Given this list of marker genes CBLC, SMAP2, ITPK1, GLO1, SLC44A1, IBTK, SLC35G1, IVD (NCBI Gene Id 3712, isovaleryl-CoA dehydrogenase), TMEM176A, GRPEL2, CCT8, SCD, RICTOR, ILVBL, ENPP3, SLC6A8, SPSB4, TMCC3, FNIP1, MAPK1IP1L, AVL9, GNAQ, KRT23, ABHD1, CA1, APH1A, RORA, CCM2L, GRAMD2B, TMEM70, WDR11, MCL1, RHOU, CMTM4, MYSM1, SERPINA7, ZC3H12C, LPL, ATP11A, TRAF4, PTGFRN, NIBAN2, TBC1D7, SLC25A39, SDR39U1, TENT2, SMURF2 (SMAD specific E3 ubiquitin protein ligase 2), HYCC1, SERPINA6 (serpin family A member 6), DLG3, here is a description of the gene set: Human Gene Set: CHANGOLKAR_H2AFY_TARGETS_UP from publication Changolkar LN, Costanzi C, Leu NA, Chen D, McLaughlin KJ, Pehrson JR (PMID 17242180) macroH2A histone variants have been implicated to function in gene silencing by several studies, including ones showing a preferential association of macroH2A on the inactive X chromosome. To examine macroH2A function in vivo, we knocked out macroH2A1. macroH2A1 knockout mice are viable and fertile. A broad screen of liver gene expression showed no evidence of defects in X inactivation but did identify genes that have increased expression levels in macroH2A1 knockouts. macroH2A1-containing nucleosomes are enriched on the coding and/or upstream regions of these genes, suggesting that their increased expression levels are a direct effect of the absence of macroH2A1. The concentrations of macroH2A1 nucleosomes on these genes are low in the livers of newborn mice, and the macroH2A1 knockout had little effect on the expression levels of these genes in newborn liver. Our results indicate that an increase in liver macroH2A1 during the transition from newborn to young-adult status contributes to a decrease in the expression levels of these genes. These genes cluster in the area of lipid metabolism, and we observed metabolic effects in macroH2A1 knockouts. Our results indicate that the function of macroH2A1 histones is not restricted to gene silencing but also involves fine tuning the expression of specific genes. Genes up-regulated in liver tissue upon knockout of H2AFY. studied in species Mus musculus